Given this list of marker genes PKP1, EVPL, TGM1, SPRR1A, SPRR2C, CSTA, SPRR2A (NCBI Gene Id 6700), RHCG, CRNN, SERPINB13, LY6D (NCBI Gene Id 8581), IL1RN, PPL, SPRR3, KRT13, TGM3, KRT16, PITX1, CRCT1, SPINK5, SPRR1B, S100A7, KRT4, CSTB, here is a description of the gene set: Neighborhood of SPRR1B small proline-rich protein 1B (cornifin) in the GNF2 expression compendium Neighborhood of SPRR1B studied in species Homo sapiens Human Gene Set: GNF2_SPRR1B